The following is a description of a gene set: A form of telangiectasis characterized by a central elevated red dot the size of a pinhead, representing an arteriole, with numerous small blood vessels that radiate out thereby resembling the legs of a spider. Characteristically, compression of the central arteriole causes the entire lesion to blanch, and the lesion quickly refills once the compression is released. Spider hemangioma studied in species Homo sapiens Human Gene Set: HP_SPIDER_HEMANGIOMA, and this is the list of marker genes: SEMA4D, GPR35, SLC37A4, MST1, TCF4